The following is a description of a gene set: Purinergic signaling Human Gene Set: WP_PURINERGIC_SIGNALING species: Homo sapiens, and this is the list of marker genes: P2RY14, P2RY13, P2RX2, P2RX6, ADORA2B, GNAT2, LPAR6, P2RY2, P2RY12, P2RX4 (NCBI Gene Id 5025), GNAI1, PANX1, GNAI3, GNAT1, P2RX7, LPAR4, ADORA2A (adenosine A2a receptor), P2RX3, ADORA1, P2RY11, P2RX5, P2RY1, GNAO1, P2RX1, P2RY6, ADORA3, GNAI2, GNAZ, P2RY10, GNA11, P2RY8, P2RY4, GNAS, GNAT3